The following is a description of a gene set: studied in species Homo sapiens part of: Signaling by VEGF The plasma membrane-associated Neuropilin receptors NRP-1 and -2 bind some of the VEGF proteins and associate with VEGF receptor proteins. NRP-1 binds VEGF-A165, -B, and PLGF-2; NRP-2 also binds VEGF-A165 and PLGF-2, as well as VEGF-A145 and -C. The Neuropilin receptors appear to act as cofactors for the VEGF receptors, increasing their affinities for specific VEGF ligands, although the importance of this function in vivo remains unclear. Reactome Pathway: Neuropilin interactions with VEGF and VEGFR, and this is the list of marker genes: KDR, FLT1, NRP2, NRP1